The following is a description of a gene set: studied in species Mus musculus Catalysis of the hydrolysis of terminal, non-reducing alpha-(1->4)-linked alpha-D-glucose residues with release of alpha-D-glucose. Mouse Gene Set: GOMF_ALPHA_1_4_GLUCOSIDASE_ACTIVITY, and this is the list of marker genes: Sis, Mgam2-ps, Ganc, Mgam, Gaa